Given this list of marker genes TSSK3, NIPBL, DLX1, BRD2, GABBR1, ANK2, MTF2, PPP2R2B, ENTPD1, FAM20C, LRP1, OSBPL7, XPO1, LENEP, PITPNM1, UBE2Z, TGM6, TOR1AIP2, MN1, SANBR, PPP2R2C, C1orf43, PAFAH1B1, HPCAL4, SULF1, CNTN2, HOXB8, SRSF2, SYNGR1, KANSL3, RTN2, FBXL20, IGFALS, ADNP, SIX4, C6orf136, HOXB4 (NCBI Gene Id 3214), FBRS, EIF5A, PATZ1, PHF12, DCN, RAB30, BRD4, SEMA6A, LRP2, LYPD1, KCNN3, CDK12, PIP4K2B, C1orf122 (chromosome 1 open reading frame 122), MLLT10, IL21R, TOB1, BOLL, NAA15, MTX1, HOXC4, TUG1, MSI1, WT1-AS (NCBI Gene Id 53590), ZNF385A (NCBI Gene Id 25946), MAP1B, BLVRB, KIF3C (kinesin family member 3C), PRELP, SCN3B, ZNF502, ZHX2, DSG3, SAMD1, CCN2, IGFBP5, KLHDC3, GSK3B, PRKCG, ITGA5, ARHGAP5, HOXC11, GRK6 (NCBI Gene Id 2870), IRF9, HMGA1, BCL6B, ATL2, KRT13 (NCBI Gene Id 3860), HOXA1 (NCBI Gene Id 3198), ONECUT1, ACOT8, MXI1, SPTB, WNT4, SHANK1, CLIC1, ATG12, TBX6, ZSWIM3, DNMT3B, ARHGAP45, AGO1, CLIP3, YBX3, LIX1L, PCDH11Y, SYVN1 (synoviolin 1), ARID1A, GRM7, CXCL14, RNF213, FES, HDDC3, INHBE, EN1, RAB35, GABPB2, KNTC1 (kinetochore associated 1), RNF145, HR (NCBI Gene Id 55806), ADAMTS12 (NCBI Gene Id 81792), PRKAG1, XYLT2, FKBP11, DCHS1, ITGB6, E2F4, ARHGAP44, CDK8, WDPCP, TMEM119, MRPL14, MAP1LC3A, BCL11A, NSUN4, PBX1, ITGA3, SIX5, WNT3, NXPH1, GATA6, ZNF532, HOXA4, ARF3, NCDN, RRP36, PTMS, LIF, EXOC3L1, JADE2, MGAT3, RCOR2, SGIP1, NLGN2, UBE2K (NCBI Gene Id 84819), NDRG2, INKA1, BHLHE22, FLI1, SIX2, CBX6, PRRX1, TCF21, KRTCAP2, PCBP4, MEA1, HNRNPA3, OAZ2 (NCBI Gene Id 4947), MEX3B, SOD3, SRCIN1, SKIDA1, EIF4G2, EFNA4, BCL11B, PADI1, SALL1, ZEB1, FOXA2, RTN3, CACNA1D, MPC2, CCR9, APOBR, RASGRP2 (RAS guanyl releasing protein 2), THBS3, AP3S1, FLT1, MIR22HG, COX14, KMT2E, H3-3B (H3.3 histone B), USP54, NFIX, HOXB13, PTPRN, RBM3, CACNA2D3, PLEKHA4, CCNYL1, FUT8, OTX2, AGPAT4, SP6, PGF, GAD1, NR1H3, PRDM5, NAT14, WDR81, NRIP3, KLF3, YRDC, NTRK3, ADD3, RSRC2, HHATL, KLF3-AS1, SEPTIN1, AMD1, NF1, SMARCA5, RPRD2, SPTBN4, TAF8, FARP1, PBX2, EIF4G1, TRIM46, HNRNPR, ST3GAL3, MGLL, SYT6, MEIS2, GNB4, MAP3K5, FGF11, PCDH11X, SLITRK3, TMEM134, ZDHHC14, GAL3ST4, CPNE8, here is a description of the gene set: Human Gene Set: MZF1_01 studied in species Homo sapiens Genes having at least one occurrence of the motif NGNGGGGA in the regions spanning 4 kb centered on their transcription starting sites. This matches the transcription factor binding site V$MZF1_01 (v7.4 TRANSFAC).